Given this list of marker genes QTRT1, EDEM2, GLYCTK, WDFY1, FAM110C, NIFK, DOK1, TMBIM6, TAL1, ITIH3, ELOVL1, PML (PML nuclear body scaffold), DOCK6, ITGB6, EHD3, THNSL2, GPRASP2, AGO1, ZDHHC17, EDC3, TM2D3, SESTD1 (NCBI Gene Id 91404), CBFA2T2, CDIPT, IPMK, NT5DC3, KMT5B (NCBI Gene Id 54794), AQP1, RSAD2, PMP22, MMRN1, SOX18, ZC3H7A, SAR1A, MARF1, LMAN2L, SMTNL1 (smoothelin like 1), PRRC1, OTUB1, HMGXB3, PLIN2, NDRG3, PRORP, CSGALNACT1, CBR3, XYLT2, P2RX1, ACAD10, RARG, EPB41L5, GTF2F1, FADS2, EPC1, OPN3 (opsin 3), FSCN1, PIK3IP1, GLUL, RBM34, VPS45, LAMP1 (NCBI Gene Id 3916), NOMO1, ACBD6, GABARAPL1, AMZ2, AHI1, SORBS1, TLR3, TMUB1, CPXM1, DDX17, SPO11, APBB1, BIRC2, HOXB4, RNF103, VPS39, URGCP, CDHR4, LANCL1, BAG1, AKTIP, TMEM72, POLR2M, LRP12, CNPY4, TMEM143, BLCAP, TSPAN32, GPAM, MTUS1, C17orf58, GSPT2, REC8, RIN2, RTRAF, TRUB2, ARAF, EHMT2, COX19, HSF4, TXNL1, TXNL4A, SAT1, SEPTIN8, SMIM7, MRPL49, WTIP, FSTL1, RPIA, ARMC3, CDK9, PLSCR1, TMCC1, MSRB2, PCED1B, CHPF2, RPL30, CIMIP1, TREML2, CAMSAP3, TBKBP1, SQLE (squalene epoxidase), LRIG2, MAPK14, PPM1H, CHAD, SPNS1, ADIPOR2, BTBD2, PKD2 (NCBI Gene Id 5311), PKP2, C11orf68, ATP6V0C, SPG7, NINJ1, RMDN3, MYO1C, ILK, ARHGEF2, MAGED1, ZFPM1, CENPV, PTTG1, TSPYL2, PAK1, GRIPAP1, TBC1D17, LXN, MED22, LIX1L, NAIF1, ZFP3, GCH1, SSBP3, TNFAIP2, TCF25, TLCD1, NXF1, MEAK7, PAFAH2, CAVIN4, LDB1, ANKIB1, FAM114A1, PBX1, FBXL5, ETV3, DDX54, RAB37, DUSP11, EGFL6, ADGRD1, SGCE, MAPK12, TOM1L2, YPEL3 (NCBI Gene Id 83719), ABHD8, NUDT18, NBAS, CBFA2T3, C3orf70, FAM219B, TRAFD1, IP6K1, KIZ, SELENON, OCIAD1 (OCIA domain containing 1), PTPN14, HCFC2, CAPG, USP27X, ERG, CSAD, KAZALD1, MYCT1, KLF9, BMX, KMT2E, RRAS, NBR1, here is a description of the gene set: Genes up-regulated in plasmacytoid dendritic cells in response to CpG oligodeoxynucleotide 1826: 1h versus 4h. CpG 1826 binds to Toll-like receptor (TLR)9, whereas influenza virus PR8 activates pDC via TLR7. Differential stimulation of pDCs is expected to result in unique activation mechanism(s) leading to a different phenotypically and functionally matured pDC We used microarrays to detail the global programme of gene expression underlying the maturation process of pDC activated with CpG 1826 and influenza virus PR8. We identified a distinct expression profile of upregulated immunomediators. Human Gene Set: GSE7831_1H_VS_4H_CPG_STIM_PDC_UP from publication Iparraguirre A, Tobias JW, Hensley SE, Masek KS, Cavanagh LL, Rendl M, Hunter CA, Ertl HC, von Andrian UH, Weninger W (PMID 18029397) studied in species Homo sapiens